Given this list of marker genes XYLT2, ABCC6, PIK3CA, XYLT1, ENPP1, TNFRSF11B, AKT1, GALNT3, GGCX, PTEN, here is a description of the gene set: Angioid streaks of the fundus species: Homo sapiens Human Gene Set: HP_ANGIOID_STREAKS_OF_THE_FUNDUS Irregular lines in the deep retina that are typically configured in a radiating fashion and emanate from the optic disc. Angioid streaks are crack-like dehiscences in abnormally thickened and calcified Bruch's membrane, resulting in atrophy of the overlying retinal pigment epithelium. They may be associated with a number of endocrine, metabolic, and connective tissue abnormalities but are frequently idiopathic.